The following is a description of a gene set: from publication Yevshin I, Sharipov R, Kolmykov S, Kondrakhin Y, Kolpakov F (PMID 30445619) Human Gene Set: SRPK1_TARGET_GENES Genes containing one or more binding sites for (SRPK1) in their promoter regions (TSS -1000,+100 bp) as identified by GTRD version 20.06 ChIP-seq harmonization. species: Homo sapiens, and this is the list of marker genes: RNU6-762P, RPL24, NSDHL, MACROD2, AFF4-DT, PTPN4, ERCC6L2-AS1, MDH1B, GOLM2, GORASP2, CCNT1, ASXL1, LGALS2, SMG5, UPF3A, DSE, PDS5A, HERPUD2, CDC20, PFKFB2, MRPS7, C6orf120, CDK13, CDC25B, SPRTN, USP54, LINC00158, ABHD13, FAM135A, ZFC3H1, BANP (BTG3 associated nuclear protein), MYEF2, CNBD1 (cyclic nucleotide binding domain containing 1), PTRH2, MTMR11, NOL11, BANF1, PAXBP1, RPL10A, ANKRD13C-DT, ATP5F1C (ATP synthase F1 subunit gamma), PLB1, LINC01440, QRICH1, OPTN (NCBI Gene Id 337928), ACADSB, TMCO1, HUWE1, HCG14, SYN3, FAM230E, RPL12, DNAJC27, SCAMP5, TRMU, ANKRD49, TTC23, GAPDHP40, COPB1, CDH13-AS2, NCAPG, SLC35B4, RAF1, SLC25A4, CTB-30L5.1, PPP4R3B (NCBI Gene Id 57223), RPS11, RBM15, WDR6, SPTBN4, GPBP1, H6PD, SAXO1, TIPIN, WDR27, RPL27A, EEF1E1, SMG7, MGME1, KLK10, ZCCHC14, CHAF1A, PXMP2, RBM26, RPGRIP1L, BZW1, STXBP4, RPS27P7, RNF167 (ring finger protein 167), YOD1, NMRAL1 (NmrA like redox sensor 1, NCBI Gene Id 57407), HSBP1, BAALC-AS1, ANAPC4, ERICH6, RPL17, DHFR2, NFYC, CNP (2',3'-cyclic nucleotide 3' phosphodiesterase), RAB33B-AS1, CETN2, TM2D3, TRIM37, FKBPL, TUBGCP5, RFC3, GRWD1, DARS1, HDAC6, MIR325, IKZF5, WDR73, OFD1, HSPA4, SEC63, EIF4A3, LFNG, MIR933, ZMYM3, EDRF1-DT, RAPGEF2, CAND1, GDI2, ZKSCAN2-DT (NCBI Gene Id 112577464), NKTR, SRSF10, KIAA1191, TMCO1-AS1, NPTN (neuroplastin), LYRM7, CLP1, ZNF420, CD2AP, DNAJC27-AS1, DCAF16, GTF2A1, STX8P1, ATF4, LUC7L2, CIAPIN1, PRR4, NOP14, AOAH, MAK16, AURKAIP1, RRAGA, FAM200B, HIBCH, EEF1E1-BLOC1S5, NCOA4, EHD1, VMP1, MAPK14, HSPH1, SF1, MIR613, COX7B, TARDBP, ITM2B, ARID2, DENR, FBXL5, SUGP1, PTPN1, TAOK1, MATR3, RNU6-1059P, TMEM44-AS1, LAMP1, LRSAM1, RPL17-C18orf32, NRBF2, SIL1, TMEM79, KSR2, MPP4, SNHG16, NFATC3, GAS8, MICOS10, TMEM209, OR6N1, PDRG1, GTF3C2, AGBL3, COASY, MAGEF1, IREB2, EIF5, IMP3, ATF2, FZD6, FBLN1, GRK4, SETDB2, RBM39, GLRXP3, DCTD, ERGIC2, RPS6, NANP, MICOS10-NBL1, PRH1 (proline rich protein HaeIII subfamily 1), FTO, DBR1, SKA3, SLU7, TXNDC11, ENSG00000221638, MSH2, MRPL57, TLN2, NCAPG2, RPL7AP41, BTBD10, ZKSCAN2, MMS22L, MAU2, RCOR3, SNORD58B, RPS28, RELCH, POLE, SHPRH, PRDX1, NSUN3, ENSG00000271860, CDC20-DT (NCBI Gene Id 105378687), GGA3, PIPOX, PGA3, ZNF286A, FASTKD2, DNM3OS, ARPC4-TTLL3, RPS2, ADAT1, ZNF286A-TBC1D26, SEC22C, HMOX2, API5, EMD, CCDC77, SLC15A4, SPAG16-DT, GTF3C2-AS1, SLC25A11, GGNBP2, CEP97, ZFP91, RAB4A, KIN, ALKAL2, ATAD3A, SNX5, MAP2K2, LRRC28, AHCTF1, HIGD1AP2, TAS1R1, TMSB4XP4, PPP1R12A, GTF2A1-AS1, EDRF1, PUDPP2, HERPUD2-AS1, PIGN, ERICH6-AS1, TAS2R14, CD2AP-DT, COQ9, PLOD2, CDC5L, ARPC4, ZFP91-CNTF, SLC25A26, XIST, MIR3130-2, SMC5, NOL9, OTOF (otoferlin), CUL3 (cullin 3), MRE11, EIF2AK2, RNU6-955P, NPEPL1, ZNF219, LINC02994, EPCIP-AS1, LINC01344, ACTRT3, EXOC8, COPB2, PURA, RAB33B, MARCHF7, RNA5SP65, OR6C68, SNORD1C, ZNF614, ANKRD13C, LPXN, RBPJ, HECW1, RAB1B, COPB2-DT, RPS19, ZNF337-AS1, NOP16, LIG4, FHIP1A-DT, CENPB, TSPYL1, CCNC, NDUFA7, RORC, KDF1, NHS, RICTOR, UBE2D3, C5orf24, ERCC6L2, EIF1AD, FSIP1, MDH2, ENSG00000212266, ETFA, LANCL1-AS1, SSR1, ARF3, TMEM18, KCNJ1, POLDIP3, UBR3, SUV39H1, SMARCA5, NAA35, METTL16, CAB39L, ZNF136, XPC, CDK12, PSMD5, COL6A3, MAD1L1, BLVRB, RGSL1, SNORA78, SMG7-AS1, NLRP7P1, LTV1, SPAG16, THAP1, THAP2, RALBP1, RBM26-AS1, SAR1A, RBM15-AS1, HIGD2A, GMPPA, SIPA1L1, ENSG00000204684, EIF4A2, HERC1, AKAP11, HMGN1P12, UBE2D3-AS1, TADA3, MIR4470, TRAPPC2, WWOX, PUF60, DNTTIP2, HNRNPH3, SPC25, SPDL1, PPP4R3B-DT, PPCDC, SF1-DT, SFTA1P, CDIN1 (NCBI Gene Id 84529), ORC1P1, SUPT5H, COX11, ANKFY1, ZZZ3, MOK, AGR2, SNHG9 (NCBI Gene Id 735301), IGF1R, ECSIT, STYXL1, P4HA3-AS1, SRCAP, MICOS10-DT, ASPH, CSDE1, RNU12, SAP18, PHF12, MIR3130-1, UHRF2, POP7, SNORD2